The following is a description of a gene set: Mouse Gene Set: GOMF_G_PROTEIN_COUPLED_GLUTAMATE_RECEPTOR_ACTIVITY Combining with glutamate and transmitting a signal from one side of the membrane to the other by activating an associated G-protein, initiating a change in cell activity. species: Mus musculus, and this is the list of marker genes: Grm7, Grm8, Grm5, Grm6, Grm2, Grm4 (NCBI Gene Id 268934), Grm1, Grm3, Grik3 (NCBI Gene Id 329940)